Given this list of marker genes CD9, CELA2A, ALOX12, SERPINE2, CEACAM1, MMRN1, IL6R, LYN, PRKCD, IL6ST, EMILIN2, EMILIN1, CTSG, ADGRG1, C1QTNF1, JAK2, HTR2A, PRKG1 (NCBI Gene Id 5592), ADAMTS18, VPS33B, TMX1, MFSD2B, PDPN, PRKCA, SYK, GP6, IL6, UBASH3B, SH2B3, PRKCQ, F11R (F11 receptor), here is a description of the gene set: Human Gene Set: GOBP_REGULATION_OF_PLATELET_AGGREGATION Any process that modulates the rate, frequency or extent of platelet aggregation. Platelet aggregation is the adhesion of one platelet to one or more other platelets via adhesion molecules. studied in species Homo sapiens